Given this list of marker genes STK35, TSPAN2, SMG7, EMC3, FAM120A2P, VEZF1, RALBP1, SLC5A12, PRIMPOL, PPP2R5A, VANGL1, CA2, ABCC4, DNAL1, NEUROD1, TMED7-TICAM2, DDHD2, ABR, TRPA1, LYRM1, SKIC3, AFF1, DST, FAM53C, STYX, OSBPL11, MAP3K8, RSBN1, CALCR, SOS1, TNFAIP8, MMP12, GFRA2, ERBB3, NAV3, WNK1, THUMPD2, PDGFC (NCBI Gene Id 56034), CD2AP, CLSTN2, WDR26, HEY1, ERMP1, ROBO1, CCNG1 (NCBI Gene Id 900), USP48, SMURF2, PHYHIPL, MAEA, SLC2A2, AVPI1, NFKB1, NSMAF, TCERG1, RASSF6, CPEB2, MAT2A, TLL1, PARD3, NCF4, RAD21, TRDMT1, GPAM, FST, PARPBP, BMP2K, CD83, QSER1, KRTAP5-11, ITIH5, GLRA3, CAPN2, UBE2Q2, PRR23B, KCNC2, CEP41, KITLG, ALCAM, FREM1, CLEC2B, SYT16, OGA, CSGALNACT1, PAK3, ABHD5, KLHL30, GTF3C3, UFM1, KDM4A, GPATCH8, TMEM161B, SGK1, ZSCAN22, SMC4, TICAM2, ZNF585A, ZDHHC5, IKZF2, HDAC4, TMEM209, LRRTM3, TMEM17, GOLPH3, ABITRAM, SEMA3G, MPP3, RBPJ, SCN7A, STX16, CEP55, TIAL1, KLF11, ACTC1, LRRTM2, SIAH1, GPR34, ALG14, PDE3B, TIPARP, TCEAL8, GALK2, KCTD12, DEFB4A, MARCHF9, TMSB15B, ARHGAP5, LAX1, REC8, RTL6, GNPTG, HACD3, ESR1, CDCA7, SOX4, MINAR1, RHBDD1, SP1, MAPK8, FAR1, SELENOP, CCDC90B, FAM3C, MTDH, LAMP3, SNX12, MYEF2, PPIC, LPGAT1, here is a description of the gene set: Genes predicted to be targets of miRBase v22 microRNA hsa-miR-299-5p in miRDB v6.0 with MirTarget v4 prediction scores > 80 (high confidence targets). Human Gene Set: MIR299_5P from publication Chen Y, Wang X (PMID 31504780) studied in species Homo sapiens